Given this list of marker genes Fadd, Tradd, Fas, Casp9, Tlr4, Casp8, Fasl, Ly96, Ticam2, Dcc, Appl1, Tnfsf10, Ripk1, Traf2, Cflar, Ticam1, Casp3, Cd14 (NCBI Gene Id 12475), Tnfrsf10b, here is a description of the gene set: Caspase activation via extrinsic apoptotic signalling pathway species: Mus musculus Mouse Gene Set: REACTOME_CASPASE_ACTIVATION_VIA_EXTRINSIC_APOPTOTIC_SIGNALLING_PATHWAY